Given this list of marker genes TYW1, TYW5, LCMT2, TYW2, TYW3 (tRNA-yW synthesizing protein 3 homolog), TRMT5, here is a description of the gene set: part of: tRNA modification in the nucleus and cytosol species: Homo sapiens Reactome Pathway: Synthesis of wybutosine at G37 of tRNA(Phe) Derivatives of wyosine are tricyclic bases found at nucleotide 37 of tRNA(Phe) in eukaryotes. The pathway of wybutosine synthesis begins with a templated guanosine residue and proceeds through 6 steps catalyzed by 5 enzymes: N1 methylation of guanosine, condensation of 1-methylguanosine with pyruvate to yield 4-demethylwyosine, addition of an aminocarboxypropyl group to yield yW-86, methylation of yW-86 to yield yW-72, methylation of yW-72 to yield yW-58, and methoxycarbonylation of yW-58 to yield wybutosine. Wybutosine may further be modified by hydroxylation and methylation. Wyosine derivatives at position 37 of tRNAs participate in translational fidelity by stabilizing codon-anticodon pairing and preventing frameshifting.